The following is a description of a gene set: Genes up-regulated in peripheral blood mononuclear cell 1d vs 0d in adults (20-50) after exposure to MRKAd5 HIV-1 gag/pol/nef, time point 1D. Comment: Additional genes induced by MRKAd5 in vivo and in vitro, identified by exon-level analysis from publication Zak DE, Andersen-Nissen E, Peterson ER, Sato A, Hamilton MK, Borgerding J, Krishnamurty AT, Chang JT, Adams DJ, Hensley TR, Salter AI, Morgan CA, Duerr AC, De Rosa SC, Aderem A, McElrath MJ (PMID 23151505) species: Homo sapiens To better understand how innate immune responses to vaccination can lead to lasting protective immunity, we used a systems approach to define immune signatures in humans over 1 wk following MRKAd5/HIV vaccination that predicted subsequent HIV-specific T-cell responses. Within 24 h, striking increases in peripheral blood mononuclear cell gene expression associated with inflammation, IFN response, and myeloid cell trafficking occurred, and lymphocyte-specific transcripts decreased. These alterations were corroborated by marked serum inflammatory cytokine elevations and egress of circulating lymphocytes. Responses of vaccinees with preexisting adenovirus serotype 5 (Ad5) neutralizing antibodies were strongly attenuated, suggesting that enhanced HIV acquisition in Ad5-seropositive subgroups in the Step Study may relate to the lack of appropriate innate activation rather than to increased systemic immune activation. Importantly, patterns of chemoattractant cytokine responses at 24 h and alterations in 209 peripheral blood mononuclear cell transcripts at 72 h were predictive of subsequent induction and magnitude of HIV-specific CD8(+) T-cell responses. This systems approach provides a framework to compare innate responses induced by vectors, as shown here by contrasting the more rapid, robust response to MRKAd5/HIV with that to yellow fever vaccine. When applied iteratively, the findings may permit selection of HIV vaccine candidates eliciting innate immune response profiles more likely to drive HIV protective immunity. Human Gene Set: ZAK_PBMC_MRKAD5_HIV_1_GAG_POL_NEF_AGE_20_50YO_1DY_ADDNL_EXON_LVL_UP, and this is the list of marker genes: RAP1GAP2, YEATS2, TRPC4AP, BRCA2, DISC1, CLIC4, RABGAP1L, SETX, CDK18, GRIPAP1, PRICKLE1 (NCBI Gene Id 144165), HIRA, GRIN3A, NFIX, DENND1B, ZNRF2 (NCBI Gene Id 223082), CD74, HEXD, FANCA, P2RY14, PLAA, SLC25A22, PRLR (NCBI Gene Id 5618), BMAL2, FARP2, FNDC3A, UBE2Z, APOBEC3G, HDX, LRRCC1, PANX1, MTMR11, GBP6, TRIM34, HPS5, RERE, IL31RA, ATP10A, TLR3, RIPK1, GBP7, RANGAP1, GCNT2 (NCBI Gene Id 880), NIBAN1, ATP10D, BCL2L14, CARS1, LONRF1, TNK2, ACSL5, LYNX1, TMTC1, ATXN7, HESX1, APOBEC3F, FMR1, NLRC5, ZNF618, PCGF5, CASZ1, DESI1, GIMAP5, NCOA7, DOCK8, PTK2B, LATS2, TEP1, PPP2R2A, SPATA13, PANK2, SRBD1, ARHGEF3, PGAP1, C1GALT1, HSD3B7, N4BP2L1, CCR5, CPEB2, CSF1, MCL1, RRBP1, UVRAG, PRKAG2, TRIM6 (NCBI Gene Id 117854), ARAP2, GART, RELB, DGLUCY, ENPP2, LCP2, PABIR3, CHI3L1, PFKP, CARM1